The following is a description of a gene set: Human Gene Set: MORF_DMPK Neighborhood of DMPK dystrophia myotonica-protein kinase in the MORF expression compendium Neighborhood of DMPK species: Homo sapiens, and this is the list of marker genes: COL14A1, ZNF132, OR2B6, ADAMTSL3, CXCL5, ITGBL1, LRP4, CAMK4, CALN1, GNA11, LINC03124, NEB, PLPPR4, TRIO, IPO9 (NCBI Gene Id 55705), CHRNB4 (NCBI Gene Id 1143), MFN1, KRT2, GLRA3, KRT34, BRWD1, GNG4, CAMTA1, NEDD4L, DMD, DMPK, CTSB, RORB, FSHR, PCM1, UBE4B, NR1I2, SLC6A2, PVR, FBXL4, GPR171, MAP2, NPFF, MAGEA8, CYP2E1, EPHB2, GJB5, ZBTB40 (zinc finger and BTB domain containing 40), GPR19, BIRC5, EPB41L1, P2RY10, KLRC4, IGKV7-3, ZNF134, IFNA1, AQP7, AMMECR1, ABCB1, KCNA5, RXRG, TNK1, ST8SIA1, PRKCA, ATXN3 (NCBI Gene Id 4287), IL13RA1, RBMXL1 (NCBI Gene Id 494115), PIK3C2A, HNF1A, CYP1A1, SLC33A1, MLLT10, MDM2, AOC4P, GUCY2F, SULT4A1, RYR3, CDC42BPA, AMOT, TSSK2, GABRB2, WBP4, MPP3, SIX6 (SIX homeobox 6), MC5R, EDIL3, CLCN3, FUT1, ZNF157, FZD5, NR3C2, PAFAH1B2, ITIH3, PHF10, F2RL1, COL19A1, ZNF33B, PSG1, FGF18, STAG1 (STAG1 cohesin complex component), GCM1, TBXT, COQ7, R3HCC1L, PAX6, CDYL, CPB2, DDX52, FOSL1, SLC46A3, BRD4, RAD51D, NTNG2, LORICRIN, RREB1, BARX2, SLC15A1, MAGEA9, POLR3F, ATP8B1, MAN1A2, NHEJ1, LDB3, PPM1E, CFH, EXOC4, IFNA10, CDC73, DRD1, POLR1HASP, SUPT3H, HTR1E, HCRTR2, CRHR1, ZSCAN26, CEP162 (centrosomal protein 162), HEPH, HSD3B2, GCA, LGI1, JRKL, RB1CC1, PCDH7, RSC1A1, FNTB, GLE1, JADE3, SPA17, TANC2, PHLDB1, COL8A1, ZNF202, SERPINA4, ELOVL6, USP46, TLE1, TBX19, APOBEC1, DNAJC22, ZBTB14, PGM3, TMEM184B, PHOX2B, MNAT1, ABO, PART1, MSH3, ZNF141, SURF2, CACNA2D1, HOXB7, ATF2, CPEB3 (NCBI Gene Id 22849), CADM4, ATP6V0A2, ABCB10, IFNA14, BRINP3, SPRR2C, YES1